Given this list of marker genes GAS6, JAM2, EXT1, GPLD1, JAM3, here is a description of the gene set: Human Gene Set: GOBP_HEMATOPOIETIC_STEM_CELL_MIGRATION_TO_BONE_MARROW species: Homo sapiens The orderly movement of a hematopoietic stem cell into the bone marrow, and its subsequent positioning within defined functional compartments in that microenvironment. A hematopoietic stem cell is a cell from which all cells of the lymphoid and myeloid lineages develop, including blood cells and cells of the immune system.